The following is a description of a gene set: species: Homo sapiens Interphalangeal joint erosions Human Gene Set: HP_INTERPHALANGEAL_JOINT_EROSIONS, and this is the list of marker genes: PTPN22, NFKBIL1, IL10, SLC22A4, CIITA, CD244, MMP2